The following is a description of a gene set: Any process that modulates the extent of synapse maturation, the process that organizes a synapse so that it attains its fully functional state. Mouse Gene Set: GOBP_REGULATION_OF_SYNAPSE_MATURATION studied in species Mus musculus, and this is the list of marker genes: C1ql2, Clstn1, Reln, Adgrb3, Adgrl1, Cdc20, Cntnap1, Neurl1a, Dab2ip, Dab1, Nrn1, Hnrnpk, Rock1, Neurod2, Disc1 (NCBI Gene Id 640053), Igsf9, Camk2b, Anapc2, Dlgap4, Nfatc4, Nrg2, Nrxn1, Fgf7, Sema7a, Rock2, Snx27, Arhgef15, Ywhaz, Ago2, Fgf22, Vps35, Nefl